Given this list of marker genes ATP6V1E1, C4orf36, PUS7L, STXBP5, HHEX, ZNF131, SRRM2, AQP10, ARHGAP5 (Rho GTPase activating protein 5), SH3GL1, DDX1, ATXN2, TRIM23, PFKP, TIGD3, SOX13, SMIM19, CASP8AP2, FBXO9, SLBP, MFSD3, SRPK2, EBF1, DTYMK, COQ2 (NCBI Gene Id 27235), CCDC32, H3C15, LIN28A, GTF2IRD2B, TCIRG1, BLTP3A, SMARCB1, AGPAT4, BRD1, C1orf216, RNF19B, RRM2, MRM3, MGST2, MAP3K11, NKX2-3, POLA1, TUBB2B, YEATS4, NFRKB, APOO, AMBRA1, CCDC74A, ITPR2 (inositol 1,4,5-trisphosphate receptor type 2), DUSP14, UBA3, PPP6C, CSNK1E, SREBF2, RLF, VRK2, CYB5A, CIAPIN1, BEX4, SLC2A11, ELOF1, BTG2, METTL6, MGAT2, LRFN1, LIN54, PIGF (NCBI Gene Id 5281), RNF138, PITPNB, CITED1, MCM2, COPG2, PDS5A, SSX1, DGLUCY, PVR, CDC25A, OTX1, UCHL5, SLC33A1, TPM3, TOR3A, YWHAG, ZNF451, SLC17A5, CAD, LSM11, C11orf71, EAPP (E2F associated phosphoprotein), COPS5, CHD3, GPATCH8, ZNF211, ALKBH7, SH3GL3, COPS3, CDKN1C, KLHL42, ANKRD11 (NCBI Gene Id 92821), ZER1, CCNK (cyclin K), RFNG, CTSL, SYVN1, METTL21A, SETX, RFC4, ZMYM4, DCAF15, SEC23IP, NAXD, NHERF2, CDC7, SLC16A5, KIFC3 (NCBI Gene Id 3801), NPM1, MFSD5, MTBP, LIN37, FBXO7, NRROS, WWC2, CD7, DELE1, LSM10, XRN2, PBDC1, ERC1, DHODH, DDA1, SLC50A1, ZNF599, RFXANK, OSTM1, HDDC2, GRN, IFT88 (intraflagellar transport 88), PPFIBP1, CORO7, POLE2, MON2, AP2A2, RPGRIP1L, LCP1, SEZ6L2, BHLHA15, INO80, ADAMTSL4, ZNF439, AP1S2, PRR5, STK38, RASGRP2, HCLS1, RPP25, KLHL8, STK32C, QPRT (quinolinate phosphoribosyltransferase), EBF2, ZNF429 (NCBI Gene Id 388522), RNF19A, HDHD5, MXD1, GRB2, RNGTT, KLHL5, PRKX, MMS22L, ZNF621, TIMELESS, KLHL17, RFC2, CIAO1, DENND4B, ZNF846, BAG6, GANC, FADD, POLA2, PRNP (NCBI Gene Id 96713), DSCC1, GALC, GLMN, FLI1, STX12, CHAF1B, R3HCC1, MNT, PFDN4, TSC1, COPS7B, NXT1, NSMF, NT5C, ACCS, RB1, C19orf53, ATXN7L3, PEF1, NR3C1, STX3, ZC3H12A, DEPDC5, UBE2N, TNPO1, PCNA, CNNM3, TACC3, RABEP1, IKBKE (inhibitor of nuclear factor kappa B kinase subunit epsilon), ANKRD12, POLB, ZNF684, KDM1B, MYLK3, SDHA, ANAPC13, MEF2C, ZNF691, CDK11B, MACO1, BRPF3, NAA30, COPRS, ZNF548, SETDB1, TOPORS, ZNF268, ST3GAL4, GFUS, ICAM5, ZNF678, MZT1, TIPIN, WDR11, NFATC2, CHCHD6, EGR1, ZNF7, CHD4, PLSCR1 (NCBI Gene Id 5359), CRY1, PBX3, GPAA1, NUP205, MCM7, NCOA7, GINS3, TIMM10B (NCBI Gene Id 26515), FYTTD1, SRI (sorcin), GCLC, SLC12A9, SCO2, PYGB, EME1, NMT1, TVP23B (trans-golgi network vesicle protein 23 homolog B), CLEC11A, TGFBR3, FZR1, HIC2, SP5, DUS3L, OLA1, TROAP, SLC25A13, POLD3, WNK2, SIX4, PAFAH1B2, ZNF358, PLD3, ATAD5 (ATPase family AAA domain containing 5), KNSTRN, MRPL45 (mitochondrial ribosomal protein L45), LRPAP1, FOXG1, MVD, EBF4, SLC39A4, TMEM164, ZBTB44, API5, FGF2, DYNC1I2, NAE1, ME2, CAPN10, CEP104, DNMT1, MDM1, MAGEA3, POGLUT1, CPSF3, HMG20A, HOXD10, UGT8, PCOLCE2, CSK, CHMP7, AKR7A2, ZSCAN1, LRRC47, CSTF2T, RFC3, ALDH1A2, NEU1, GRPEL2, BECN1, ABHD17A, PBK, RNF103, UBE2D1, MIA2, KRTAP4-7, ATAD3A, GTF2I, GLOD4, PRIM2, HEXD, PDP2, CAMK1, UBE2W, PHRF1, RTN3, ARAP1, ARMC1, POLD2, GPS2 (G protein pathway suppressor 2), GALK1 (NCBI Gene Id 2584), FOXL1, TSPAN4, HNRNPDL, DCAF16, CBFA2T3, LIMD2, SMARCA2, SLC25A29, RFX6, PITPNA, NOC4L, PIK3CD, NABP2, PCK2, PRKAB1, SMDT1, NR1I3, GMPR2, USP42, MCM3, PIR, MYH10, UNKL, SLC9B1, ATG2A, DYNLL1, CYB561D2 (NCBI Gene Id 11068), NRF1, RAB13 (RAB13, member RAS oncogene family), NAGA, GINS4, UBN2, IREB2, MAP1A, YWHAB, EN2, ADIPOR2, PHACTR1, TRMT10A, GMFG, ACAA2, EVL, MKRN1, ZNF85, FIGLA, FOXN1, H2BC4, PSMB5, WDHD1, ZNF641, PIGH, KCNA10, OSBPL3, ZNF396, KLF7, PCGF5, CCNT2, REEP3, TIGD5, SPATA24, OR4F4, GON4L, SHQ1, STX10, ARL6IP4, VAMP4, RFC5, NUDCD1, KEAP1, ANKRD16, ASCC1, SLC35B4, PPP1R16A, RTL8C, CHFR, PAQR3, BLCAP, TBXA2R, PTPN2, RBBP8 (NCBI Gene Id 5932), BCKDK, POLQ, DOCK9, USP25, PCCB, MTF1, MEST, MCM6, RRAGB, SAV1, ZNF852, ACTR8, LIN28B, AKR1C2, FOXL2, PHYHD1, RBL1, PDLIM5, DUSP11, NCK2, PAAF1, SETD6, PDXK, RPS3, ERV3-1, DESI1 (NCBI Gene Id 91610), APOBEC3G, RNF8, TUBB6, WAS (NCBI Gene Id 7454), ORC6, POLD1, ZNF529 (zinc finger protein 529), POLE, PLEKHF1, ZNF419, here is a description of the gene set: Human Gene Set: PULVER_FOREY_PERTURB_ATTRITION_LG1 Transcription regulation during the cell cycle is crucial for ensuring genes are expressed at the right time and in the correct amounts, coordinating key processes like DNA replication, mitosis, and cell division. In our study, Genes whose depletion leads to accumulation of cells in lG1 (pVal < 0.05) in K562 Repogle et al., 2022 reanalyzed with Velocycle from Lederer et al., 2024 studied in species Homo sapiens